Given this list of marker genes H3c15, Nup85, H3c3, Rb1, H2ac7, Nup205, H3c4, Lmna, H4c6, H2bc9, Aaas, Ncapd3, H2ac15, Nup155, H4c17, Nup58, H2bc22, Ccnb1, H2bc13, H2ac20, H2ac8, Rae1 (ribonucleic acid export 1), Nup42, H2ac12, Blzf1, Golga2, Ctdnep1, H3c10, H4c8, H2az2, Nup54, H2ac24, H2bc7, H3c11, H3f3a, Vrk1, Ncapg2, Gorasp1, Nup210, H2ac13, H4c14, H2bc12, Ndc1, H2ac23, H4c2, H2ac11, H2ac1, Seh1l, H2ac19, Rab1a, Lmnb1, H2ac6, H3c2, Cdk1, Vrk2, H2bc1, H4c1, Plk1, H3c7, H4c3, H3c1, Rab1b, Mapk3, H4c4, H2ac10, Nup133, H2ac22, H4c9, H4c11, H3c13, H2bc3, Emd, H2bc8, H2ax, H2bc27, H4c12, H2bc11, Nup93, H2ac4, H3c6, H4c18, H3c8, H2bc15, Prkca, here is a description of the gene set: studied in species Mus musculus This event has been computationally inferred from an event that has been demonstrated in another species.<p>The inference is based on the homology mapping from PANTHER. Briefly, reactions for which all involved PhysicalEntities (in input, output and catalyst) have a mapped orthologue/paralogue (for complexes at least 75% of components must have a mapping) are inferred to the other species. electronically inferred by orthology from the curated human pathway part of: M Phase Reactome Pathway: Mitotic Prophase